The following is a description of a gene set: species: Mus musculus Mouse Gene Set: GOBP_DETERMINATION_OF_DORSAL_VENTRAL_ASYMMETRY Determination of asymmetry from the dorsal to the ventral side; as, the dorsoventral axis., and this is the list of marker genes: Grem1, Nbl1, Acvr1, Cer1, Grem2, Ddit3, Mapk8, Sostdc1, Aida, Ctnnb1, Map3k4